The following is a description of a gene set: Genes up-regulated in comparison of monocytes treated with anti-TREM1 versus monocytes treated with 1 ng/ml LPS (TLR4 agonist). Human Gene Set: GSE9988_ANTI_TREM1_VS_LOW_LPS_MONOCYTE_UP studied in species Homo sapiens TREM-1 is an orphan immunoreceptor expressed on monocytes, macrophages, and neutrophils. TREM-1 associates with and signals via the adapter protein DAP12/TYROBP, which contains an immunoreceptor tyrosine-based activation motif (ITAM). TREM-1 activation by receptor cross-linking is pro-inflammatory, and can amplify cellular responses to Toll-like receptor (TLR) ligands such as bacterial lipopolysaccharide (LPS). To investigate the cellular consequences of TREM-1 activation, we have characterized global gene expression changes in human monocytes in response to TREM-1 cross-linking in comparison to and combined with LPS. Both TREM-1 activation and LPS up-regulate chemokines, cytokines, matrix metalloproteases, and PTGS/COX2, consistent with a core inflammatory response. However, other immunomodulatory factors are selectively induced, including SPP1 and CSF1 (i.e., M-CSF) by TREM-1 activation and IL-23 and CSF3 (i.e., G-CSF) by LPS. Additionally, cross-talk between TREM-1 activation and LPS occurs on multiple levels. While synergy in GM-CSF protein production is reflected in commensurate mRNA abundance, comparable synergy in IL-1b protein production is not. TREM-1 activation also attenuates the induction of some LPS target genes, including those that encode IL-12 cytokine family subunits. Whereas positive TREM-1 outputs are abolished by the PI3K inhibitor wortmannin, this attenuation is largely PI3K-independent. These experiments provide a detailed analysis of the cellular consequences of TREM-1 activation, and highlight some of the complexity in signal integration between ITAM- and TLR-mediated signaling. from publication Dower K, Ellis DK, Saraf K, Jelinsky SA, Lin LL (PMID 18292579), and this is the list of marker genes: TXNIP, SERTAD3, S1PR3, DTL, PHAF1, BCAR3, SGK1, USP4, TMEM121B, SCARB2, TLE3, TLR5 (NCBI Gene Id 95519), LONRF3, LPIN1, ZNF668, PLCXD1, ACSL3, UBXN7, GNA13, SH3BP5, BLOC1S3, LBX2-AS1, CCR1, ANKRD28, ATP6V1G1, UBR7, AMD1, TLNRD1, PLEKHM1, NRIP3, MAP4K3, IL17RA, DNMBP, FBXO7, DUSP14, PTPN6, PEX5, SLC8B1, LINC01010, UBASH3B, PLEKHO1, BRI3 (brain protein I3), TMEM38B, ACVR1, RNASEK, RREB1, ARL6IP1, MT1F, LINC00900, COA7, SLC37A2, NAA50, ZNF324, CEBPB, SNX8, RIOK3, MT1H, WDR91 (WD repeat domain 91), IMP3, TEX261, MAP1LC3B, SPRING1, KLHL26, PHF13, OLIG1, KLF2, PNP, BCKDK, TNFSF14, HAVCR2, MT1HL1, LIMK1, STARD5, LPL, GTF2IRD1, SDS, EIF2AK3, RARA, CLN8, RRAGD, BCAP31, DAB2, VKORC1, IFI30, FAM131A, ADCK2, CHST15, PCYT1A, LHFPL2, SPART, GPCPD1, CENPBD1P (CENPB DNA-binding domain containing 1, pseudogene), NEU1, HSD3B7, TMBIM1, DHRS9, MT2A, PHF23, GPNMB, CHSY1, NPC1, FBXO45, ATOSB, SLC38A7, ZNF592, EIF4A1, LRFN4, PLEKHM2, ZC3HC1, ZCCHC2, TGIF1, MELTF, FABP5, SNX12, CD300LB, STX3, SDSL, SYN2, ATP6V1B2, PPARG, SNX33 (sorting nexin 33), RRAGC, ORAI3, PSD4, HIC1, TGFBR1, LY9, FBXL5, NRBP1, LASP1, ATP6V1D, STX1A, SLCO4A1, CLTA, MT1X, GNPDA1, MT1G, PPP2R5A, DDI2, SNUPN, TM2D2, CORO1C, CNST, TMEM70, MGAT1, KCTD7, MT1E, KLHL6, SLC1A4, GFOD1, BLMH, MIEF1 (NCBI Gene Id 54471), CCDC97, FNIP2, PLPP3, STX4, TNFSF15, TBC1D7, CRTAM, SMIM13, HEXB (hexosaminidase subunit beta), OLIG2, SNX9, ZNF318, PPFIA1, CTSL, TRIM33, TBC1D2, SPP1, TMED5 (NCBI Gene Id 50999), NDUFB2, LONP1, LYSET, NRROS, CD63, TMEM9B, MCOLN1, TRIB1, ASPH, RHOB, MOAP1, MMP19, DYNLT2B, HMCES, CYTH4, PLEKHO2, PI4K2A, ATF3, S100A2, COL15A1, CAMSAP1, EFR3A, LGALS3, TCEAL9, TMEM273, FKBP15, NPM1, CD164